The following is a description of a gene set: Human Gene Set: GOMF_GTPASE_BINDING species: Homo sapiens Binding to a GTPase, any enzyme that catalyzes the hydrolysis of GTP., and this is the list of marker genes: CDC42EP1, RNF152, RIMS4 (NCBI Gene Id 200225), IPO8, PKN2, CDC42EP4 (CDC42 effector protein 4), USP33, RGPD8, TNFAIP1, RRAGC, ULK1, VPS9D1, RBSN, FGD5, BICDL2, LRRK2, TBC1D30, TBC1D20, BICD1, RANGRF, GIT2, FNBP1L, RALBP1, ARHGAP44, MYO5B, RABGGTB, NOXA1, ENO1, RASSF1, FMNL2, WHAMM, ABCA1, DAAM2, PDE6D, RNF41, CSE1L, SOD1, RIN3 (NCBI Gene Id 79952), IPO4 (NCBI Gene Id 79711), RIMS2, EPRS1, RASA1, IQGAP3, STRIP1, EXOC8, RANBP10, MAP3K11, IQGAP2, RAB3IP, RINL, CIMAP3, RPH3A, RAP1A, DOCK7 (NCBI Gene Id 85440), DVL1, ERC1, ROCK1, HPS6, TBC1D7, PLEKHG1, DOCK2, RCC2, TAMALIN (trafficking regulator and scaffold protein tamalin, NCBI Gene Id 54408), ATG14, CDC42SE1, GCC2, AP1G1, LSM2, EHD1 (EH domain containing 1), RANGAP1, DIAPH3, GNB2, SIKE1, CDC42SE2, GCC1, GIT1, BICD2, FMNL1, SYTL4, CYRIA, PRKCH, GNB3, IFT20, TMEM127 (NCBI Gene Id 84178), ARHGEF2, MAP2K1, STOML2, GDI1, EVI5L, C9orf72, YIPF2, DENND5B, GARRE1, PARD6A, DAAM1, TSC2, SH3BP4, ARHGAP1 (Rho GTPase activating protein 1, NCBI Gene Id 392), YBX1, EVI5, BRAF, RADIL, WAS, NDRG1, CDC42EP3, AP3M1, KCTD13, MLPH (melanophilin), EXPH5, RAB34, CYRIB, RTKN, WDR44, DIAPH2, RANBP2, PAK3, ATG16L1, RPTOR, XPO7, RIMS1, TRIP11 (thyroid hormone receptor interactor 11), IPO11, GOLGA5, MYO5A, CHML, EPS8, NUTF2, ANKRD27, UNC13D, NPC1L1, ITPKA, GAS8, FGD4, RIN2, RGL3, DOCK4, OCRL, NXT1, IPO5, SPHK2, RAPGEF4, STRN3, RABAC1, XPO1, UNC13B, MICALL2, NOX1, TNPO3, RABGEF1, SYTL2, CDC42EP5, SGSM1, ERRFI1, DOCK11, XPOT, ATP6AP1, ALS2CL, RANBP17, TBC1D21, LAMTOR1, FGD3 (FYVE, RhoGEF and PH domain containing 3), RRAGD, TBC1D13, RIC1, CDKL5, YBX3, CAV1, TNPO2, XPO6, DAPK3, WASF1, IPO7, PLCE1, RABGGTA, GGA1, SRGAP2, USP6NL, RHOBTB3, DIAPH1, CHM, RRAGB, ABI2, RAPGEF6, RAB11FIP3, CLTA (NCBI Gene Id 63271), KIF3B, BICDL1, PAK1, KPNB1, CYFIP2, RAB3GAP2, RAB11FIP4, AIMP1, PAK2, MARCHF5, XPO5, MYO1C, IARS1, FARP1, DOCK1, PEX5L, FGD2, PLEKHG3, BIRC5, RAF1, MYO9B, FGD6, FMNL3, RPH3AL, XPO4, NCF2, ARHGDIB, GDI2, CYFIP1, RILPL2, IQGAP1, CDC42EP2, DVL3, GGA3, MICALL1, CCDC186 (coiled-coil domain containing 186), ROCK2, GRIA1, RIMS3, ARHGEF16, HSP90AA1, SGSM3, SRGAP1, MAPKAP1, RAB11FIP2, DNM1L, PKN3, MYCBP2, RANBP3, PEX5, RAB3GAP1, FLNA, PICALM, RUSC2, RAB11FIP5, GGA2, PFN1, RAB7A, KIF3A, BECN1, INF2, ODF2, NME4, KNTC1, CIB1, DMXL2, ARFIP2, AMBRA1, RHOH, HDAC3, BNIP3, ANKFY1, POU4F1, DEPDC5, NCKAP1, YIPF1, AKAP13 (NCBI Gene Id 84122), DENND5A, RILPL1, RASIP1, SYTL5, SYTL1, MTSS2, PREB, HACE1, BRK1, DOCK5, RAB29 (NCBI Gene Id 8934), SORL1, PKN1, RABGAP1L (NCBI Gene Id 9910), DECR2, RGP1, EXOC5, DVL2, HPS4, CORO1C, C15orf62, DOCK10 (NCBI Gene Id 9714), AFDN, MICAL1, SYTL3, RABGAP1, RAB11FIP1, GAPVD1, MYRIP, RASGRP3, NGFR, PPP6R1, PLEKHG2, GOLGA4, ALS2, TNPO1 (NCBI Gene Id 3842), RAB8A, LZTR1, TRIOBP, DOCK3, EXOC2, DENND10, ADCYAP1R1, RANBP9, ECT2, BIN1, DENND1B, RANBP1, PIH1D2, GNB1, RIN1, RCC1, IPO9, FGD1, IPO13, RAP1GAP, SGSM2, RILP, LCP1, SPTBN1